Given this list of marker genes Acat3, Adamts5, Ric1, Usp32, Syt1, Cyria, Myrf, Zfp362, Sf3b4, Snrk, Wasf2, Dmxl1, Elfn1, Arpc5, Cdyl2, Glra2, Gab2, Kctd20, Tfap2d, Myh9, Virma, Jazf1, Tbpl1, Gpm6a, Fam163b, Sfxn5, 2700062C07Rik, Ppfia1, Lhfpl6, Tmod3, Simc1, Fam199x, Cacna1b, Otc, Fbn1, Rab5c, Pitpnm2, Epha7, Ankrd12, Celf1, Prrt2, H2-Aa, Arrb1, Cmpk1, Lrrfip1, Cap1, Edem1, Scyl3, Dnah11, Vps54, Timm17a, Zc3h14, Ago1, Clta, Slc25a39, Xpo1, Hpcal4, Agt, Ankrd28, Ptprz1, Nup153, Eif4a1 (NCBI Gene Id 13681), Papln, Kmt2c, Yes1, Ptbp3, Sgpp1, Kcna6, Tmem167, Sobp, Gabarapl1, Rap2c, Kat5, Sec61b, Serpina12, Sf3b1, Sacm1l, P2rx4, Arfip2, Sephs2, Ebf2, Elavl1, Pfn2, Pcgf2, Rarb, Smarcd1, Rb1cc1, Sh3tc1, Mmgt1, Foxc2, Faim, Fads1, Bicc1, Arhgap12, Sumo1, Tagln2, D5Ertd579e, Peak1, Praf2, Mllt3 (NCBI Gene Id 77576), Gdnf, Foxl2, Ankrd44, Emp2, Acat2, Slc6a1, Tafa5, Sgms2 (NCBI Gene Id 99755), Irf2, Phf24, Tspan15, Grm5, Hs2st1, Ube2q1, Mtmr4, Aftph, Braf, Tpd52l1, Ckap4, Ppp2ca, Zfp280c, Dusp1, Tent5a, Dhx32, Afap1 (actin filament associated protein 1), Riok2 (RIO kinase 2), Sh3gl2, Fam117b, Tfg, Slc50a1, Btbd3, Snx30, Vat1, Raph1, Actn4, Med12l, Sirt1, Rbmx, Fbxl2, Vps13a, Sec61a1, Pik3c2a, Dolpp1, Ptpro, Zfp131, Sgk1, Ppp2r2d, Ptbp1, Dmxl2, Rbpj, Maml1, Dpysl4, Shisa5, Rffl, Plekha3, Enc1, Map4, Lhx5, Fgf1, Cnn2, Rab30, Col25a1, Lasp1, Hsd17b11, Ncald, Aldh1a3, Uba2, Tent4b, Garnl3, Tax1bp1, Kcnd3, Pan3, Ldlrap1, Dusp28, Fam117a, Sp3, Gatad2a, Plpp2, Dync1li2, Lsp1, Actr1a, Prrx1, Celf4, Ctbp2, Xylb, Cbll1, Msn, Fhip2a, Nup160, Adcyap1, Gabpb2, Sertad4 (NCBI Gene Id 214791), Ppp2cb, Il1rapl2, Pax7, Selenof, Thrap3, Csnk1g3, Pex5l, Nell2, Spn, Ube2q2, Slc30a7, Foxp4, Arhgef9, Eya1, Ttyh3, Zc3h11a, Aif1l, Cul4b, Lancl2, Mmp15, here is a description of the gene set: studied in species Mus musculus Mouse Gene Set: MIR_133A_3P_MIR_133B_3P from publication Chen Y, Wang X (PMID 31504780) Genes predicted to be targets of miRBase v22 microRNA mmu_miR_133a_3p, mmu_miR_133b_3p in miRDB v6.0 with MirTarget v4 prediction scores > 80 (high confidence targets).